The following is a description of a gene set: Human Gene Set: GSE35685_CD34POS_CD10NEG_CD62LPOS_VS_CD34POS_CD10POS_BONE_MARROW_DN Studies of adult human hematopoiesis have until now relied on the expression of CD10 to define lymphoid commitment. We report a novel lymphoid-primed population in human bone marrow that is generated from hematopoietic stem cells (HSC) prior to the onset of CD10 expression and B cell commitment, and is identified by high levels of the homing molecule L-selectin (CD62L). CD10-CD62Lhi progenitors have full lymphoid (B/T/NK) potential, and show reduced myeloid and absent erythroid potential. Genome-wide gene expression analysis demonstrates that the CD10-CD62Lhi population represents an intermediate stage of differentiation between CD34+CD38- HSC and CD34+lin-CD10+ progenitors marked by down-regulation of TAL1 and MPL, upregulation of E2A, CD3E and IL2RG expression, and absent B cell commitment or RAG1/2 expression. Immature CD34+CD1a- thymocytes are also CD62Lhi and L-selectin ligands are expressed at the cortico-medullary junction, suggesting a possible role for L-selectin in human thymic homing. These studies identify the earliest stage of lymphoid priming in human bone marrow. from publication Kohn LA, Hao QL, Sasidharan R, Parekh C, Ge S, Zhu Y, Mikkola HK, Crooks GM (PMID 22941246) Genes down-regulated in the bone marrow CD34+ cells: MME- SELL+ versus MME+. species: Homo sapiens, and this is the list of marker genes: MAP4K4, ZFAND5, IL13RA1, SLFN12L, CCL4, GBP7, LGALS8, JUN, AP1B1, TWF1, FCGR1A, EPAS1, CTSC, LCP2, CCL2, KRT25, CXCL10, ST6GALNAC4, BZW2, ISG15, HOXA1, MORF4L2, NSMCE1, STAT1, IKZF1, STAT3, SLC41A1, SELP, C11orf16, GADD45G, SKAP2, ZNF281, CCL13, RUNX2, C9orf72, GBP2, PNP, NDRG1, IL15RA, GAB1 (GRB2 associated binding protein 1), PTPN1, FCGR2B, MPHOSPH10, ASAP1, MLX, TINF2, ALKBH5, LY6E, NID1, IER3 (immediate early response 3), VCAN, CNN3, MAP3K8, GCNT2, FARSA, ENPP1 (NCBI Gene Id 5167), MX2, KDR, CH25H (cholesterol 25-hydroxylase), FGL2, ITPKB, TNFRSF1A, CASP6, ASL, MYD88, SLC44A2, PIK3R1, TIMP1, SLC11A2, HTT, CCR1, MANF, NFKBIZ, FLOT2, MAP3K2, OSBPL11, RIOK1, ABHD16A, HSD17B10 (hydroxysteroid 17-beta dehydrogenase 10), NSF, SOCS1, RAB5C, MAFB, TAP1, NABP1, CASP1, PML, RAB8B, CD86, MGAT1, COCH, AP2A2, CEBPD, TSPAN13, ALDH1A1, TNFAIP8, SNX1, CD244, TM2D2, CASP4, ADA, DUSP16, CSF2RB, BMP2K, MARCHF5, ITSN1, TGFBI, ARFIP2, NDEL1, AMOTL2, TSPAN9, IRF1, IST1, CWF19L1, ATP6V0A1, RAB11FIP5, DAB2, SLC12A7, SUSD6, BOLA3, EIF1AY, LGALS9B, JAK3, TBC1D14, CMTM6, KCNJ6, HMOX1, MXD1, PNPT1, PSMB9, ATF6, CCL22, FH, AGFG1, VMP1, PRSS58, NAMPT, UNC13B, SEMA3E, STX12, TIMM10B, ENSA, SLC35B1, ZFP36, PSMB10, TPST1, PROS1, TSPO, EDNRB, UBE2K, PLA2G4A, GBP4 (NCBI Gene Id 115361), GJA1, HSPA8, STAT5A, MIF, TLR6, SNRPA, ENG, IL18BP, FOXB1, IRGM, MCOLN2, B4GALT3, SNX6, CCL7, ITGB1BP1, CD53, IFITM3, SF3A1, PIM1, ADAM9, MIDN, SNAP25, INPP5B, HSPA5, PLSCR1, FABP5, RAB1A, VRK3, TLK2 (tousled like kinase 2), BCL3, LITAF, NPPC, IL4R, PRAF2, TLE3, SEC16A, IFIT2, JARID2, ATP6V0C, FZD3, APAF1, RWDD4, KIF3A, LTB4R, RAB3IL1, KRTCAP2, CHD7, RAB4B